The following is a description of a gene set: part of: FGFR2 mutant receptor activation species: Homo sapiens Reactome Pathway: Signaling by FGFR2 IIIa TM A soluble truncated form of FGFR2 is aberrantly expressed in an Apert Syndrome mouse model and inhibits FGFR signaling in vitro and in vivo. This variant, termed FGFR IIIa TM, arises from an misspliced transcript that fuses exon 7 to exon 10 and that escapes nonsense-mediated decay. FGFR2 IIIa TM may inhibit signaling by sequestering FGF ligand and/or by forming nonfunctional heterodimers with full-length receptors at the cell surface., and this is the list of marker genes: NCBP1, POLR2G, POLR2E, FGFR2, POLR2C, FGF2, POLR2H, FGF1, POLR2L, POLR2I, POLR2F, GTF2F2, NCBP2, POLR2K, POLR2B, GTF2F1, POLR2J, POLR2D, POLR2A